Given this list of marker genes TPD52, ACBD3, NECAP1, BLOC1S6, CLTC, RAB5C, VAMP8, PIK3C2A, TFRC, PICALM, CLTA, AP4E1, VAMP7, FTL, SNX9, ARRB1, GOLGB1, SH3GL2, AP1M2, DTNBP1, HIP1R, YIPF6, GAK, BLOC1S1, SNX5, TGOLN2, TXNDC5, PUM1, VAMP2, AP1S1, AP3S1, NAPA, AP1S2, SORT1, AP1S3, BLOC1S4, FTH1, IGF2R, HSPA8, AP4B1, DNAJC6, AP3B1, BLOC1S3, SNX2, CLINT1, AP1B1, SH3D19, TPD52L1, DNM2, AP1M1, ARF1, SNAPIN, CPD, AP1G1 (adaptor related protein complex 1 subunit gamma 1), OCRL, TBC1D8B, here is a description of the gene set: species: Homo sapiens Golgi Associated Vesicle Biogenesis Human Gene Set: REACTOME_GOLGI_ASSOCIATED_VESICLE_BIOGENESIS